Given this list of marker genes NGFR, NRAS, PRKAR2B, MYC, ITGB8, ITGA10, CDH9, PAK3, ITGAD, TEAD3, CTNNB1, MST1, ITGA4, ITGB5, CDH18, IGF1R, ITGA2B, PAK4, CDH8, CDH19, SAV1 (salvador family WW domain containing protein 1), PRKACA, PAK2, CDH15, CDH11 (cadherin 11), EGFR, TEK, PPP1R14A, PPP1CC, VGLL4, ITGB2, CDH16, PPP1R12A, MIR98, CTNNA1, PPP1CB, LATS1, PAK1, ITGA8, PRKAR1A, ITGA1, ITGB6, NTRK2, ITGA2, CSF1R, PPP1CA, PRKAR1B, ITGA5, CDH6, CDH17, CDH3, PRKACB, MET, HRAS, ITGAL, ITGAX, FLT4, EPHA2, CDH10, ITGB7, CDH13, CDH4, KRAS, CDH5, CXCL10 (NCBI Gene Id 3627), BUB1B-PAK6, RBX1, CCN2, KIT, FLT3, AJUBA, STK3, FLT1, ITGA7, DDB1, CDH2, YAP1, PAK5, ITGA6, ITGAV, CD44, CUL4A, CDH12, ITGAE, FGFR1, FGFR4, ITGA11, ITGAM, TEAD4, CDH1, PRKACG, PDGFRB, CDH7, ITGB1, NF2, CDH22, WWTR1, PDGFRA, LATS2, PRKAR2A, ITGA9, TEAD2, PTK2, PAK6, DCAF1, LIN28B, ITGB4, FOXM1, INSR, CCND1, AMOT, NTRK1, PLCB4, FGFR2, ITGA3, TEAD1, ITGB3, CDH20, KDR, CDH24, FGFR3, here is a description of the gene set: Human Gene Set: WP_HIPPOMERLIN_SIGNALING_DYSREGULATION studied in species Homo sapiens Hippo-Merlin signaling dysregulation